The following is a description of a gene set: Human Gene Set: KEGG_MEDICUS_REFERENCE_P16_CELL_CYCLE_G1_S species: Homo sapiens p16-Cell cycle G1/S. Pathway ID: N00069. Pathway type: Reference. Pathway class: nt06262 Pancreatic cancer. Pathway Definition from KEGG: CDKN2A -| (CCND+CDK4/6) -> RB1 // E2F, and this is the list of marker genes: CCND3, CDK6, E2F1, CDK4, CCND1, CDKN2A, E2F3, RB1, CCND2, E2F2